The following is a description of a gene set: Neighborhood of MCM4 MCM4 minichromosome maintenance deficient 4 (S. cerevisiae) in the GNF2 expression compendium Human Gene Set: GNF2_MCM4 Neighborhood of MCM4 species: Homo sapiens, and this is the list of marker genes: RFC3, CKS2, RFC4, TTK, PA2G4, TYMS, ASPM, TCP1, NDC80, RACGAP1, BUB1, MCM3, MCM5, UBE2C, SMC4, NASP, MCM4, CCNA2, GMNN, KIF18B, GINS1, CENPM, MELK, ZWINT (ZW10 interacting kinetochore protein), FANCI, CDC20, KIF14, KIF11, FOXM1, MCM2 (NCBI Gene Id 94687), HMMR, FEN1, GINS2, RRM1, CDCA8 (NCBI Gene Id 55143), ESPL1 (extra spindle pole bodies like 1, separase), PCLAF, LMNB1, MCM7, MAD2L1 (mitotic arrest deficient 2 like 1), POLD1, AURKB, RAD51AP1, BUB1B, PCNA, HELLS, ASF1B, AURKA, TOP2A, MCM6, CCNB2, PAICS, RRM2